Given this list of marker genes FMN2, AIF1, ESPN, SPIRE2, USH1C, SPIRE1, FSCN1, here is a description of the gene set: Human Gene Set: GOBP_PARALLEL_ACTIN_FILAMENT_BUNDLE_ASSEMBLY Assembly of actin filament bundles in which the filaments are tightly packed (approximately 10-20 nm apart) and oriented with the same polarity. studied in species Homo sapiens